The following is a description of a gene set: Human Gene Set: GSE32423_IL7_VS_IL7_IL4_NAIVE_CD8_TCELL_DN Genes down-regulated in comparison of naive CD8 T cells treated with IL7 versus those treated with IL4 and IL7. studied in species Homo sapiens Effects of IL-4 on CD8 T cells functions are largely unknown. IL-4 induces survival and proliferation of CD8 T cells, but several studies suggest that IL-4 could also affect several functions of CD8 T cells such as cytotoxicity. Our team has shown that IL-4 repress the expression of Ccl5 in vitro. To define more precisely the impact of IL-4 on CD8 T cells, we performed a whole genome expression microarray analysis of naive and memory CD8 T cells cultured in presence or absence of IL-4. This approach allowed us to define the IL4-gene-expression signature on CD8 T cells. from publication Ventre E, Brinza L, Schicklin S, Mafille J, Coupet CA, Marçais A, Djebali S, Jubin V, Walzer T, Marvel J (PMID 22942430), and this is the list of marker genes: ERO1B, DIS3L, VPS50, USP2, YAF2, RSRC2, CEP57L1, EMSY, DDB2, ATP6V1A, MAN1A1, TTC9C, MST1, DBR1, GPR179, BAIAP3, APLN, PTBP2, PRSS37, TNFSF10, TNFRSF14, RDX, UBE2J1, LATS1, SLC38A9, INTS6L, ELF1, LSS, WDR47, VAMP7, COL6A3, HMGCR, LKAAEAR1, CEP170, FASTKD3, DHRS3, TRAT1, ZNF131, RBL1, PLEKHM1, CPEB4, NR1I2, DNAJB11, DLG2, NDFIP2, RABGAP1, TUBE1, HNRNPH1, XBP1, C9orf152, ITM2B, APBB2, ARID5A, DLX1, DUSP10, SCAF8, PALS1, TMEM41B, CCNB3, SCML4, SRSF7, ZMYND11, SRBD1, UST, PTPN3, SLC39A6, BCL2L13, PKN2, CYFIP2, EPC2, ZNF516, RCOR1, SLC35A5, GCC1, LMAN2, PAPSS2, XDH, SMO, ASB3, CUL4A, SPATC1L, KLHL7 (NCBI Gene Id 55975), ATP11A, SMAP2, GPRIN3 (GPRIN family member 3), AQP3, PPTC7, C21orf58, GALNT7, CSGALNACT2 (chondroitin sulfate N-acetylgalactosaminyltransferase 2), TRIP4, PLRG1, DNAJA4, HSD11B1, INO80C, SFT2D2, USP33, DLX2, ATAD5, ZNF277, TMED7, TOPORS, CST7, HSD17B12, TRAPPC14, RAB8B, GJA4, STAT2, CLIP2, CMPK2, BCL6, ADSS2, NANOS1 (nanos C2HC-type zinc finger 1), P2RY10, HDAC2, MAP7, HPN, CREBZF, N4BP2L1, PRPS1, LCP2, MBIP, DNAJC7, PRDM1, RBM25, MTUS2, WDR20, ALDH3B1, PPP4R3B, EVL (Enah/Vasp-like), ATOSA, DDX3Y, HOMER1, FGFR1OP2, YTHDF3, BMI1, ZFAND5, AR, GIMAP1, GIP, CALU, EHHADH, PPP3CC, P2RX7, MTFR2, MTREX, NAPB, B3GALT4, ODAD4 (outer dynein arm docking complex subunit 4), LOXL4, CERCAM, GABPA, TPD52, IRF7, NAV1, PPIP5K2, ITM2A, TAF2, ADNP2, PTCD3, PDCL, ACTR6, MGAT1, CFAP97, ZMAT1, FYB1, RRAGD, LYST, GATA1, PRDM15, TXNDC15, KMT5B, CNPY1, TMCO3, PDIA3, PNPLA6, SLC2A6, IL9, CD247, CNKSR3, PCBP2, DIDO1, CBX4 (NCBI Gene Id 8535), TST, PLAC8, FBXO24, TMEM161B, COP1, ADGRG5, DARS1, KCNE5, SCFD1, PHKB, AHCYL2, TAF9B, PTDSS2, LDHD, CHUK, SLFN13, SEH1L